The following is a description of a gene set: A process in which a protein is transported to, or maintained in, a location within a cytoplasmic stress granule. Human Gene Set: GOBP_PROTEIN_LOCALIZATION_TO_CYTOPLASMIC_STRESS_GRANULE studied in species Homo sapiens, and this is the list of marker genes: YBX1, DCP1A, PAK1, TIA1, SSB, DDX3X, DDX1, DHX9 (DExH-box helicase 9)